The following is a description of a gene set: species: Mus musculus Combining with a protein hormone to initiate a change in cell activity. Mouse Gene Set: GOMF_PROTEIN_HORMONE_RECEPTOR_ACTIVITY, and this is the list of marker genes: Fgfr3, Mup2 (NCBI Gene Id 17841), Adipor1, Ntrk2, Tek (TEK receptor tyrosine kinase), Ntrk3, Ntrk1, Tie1, Ephb1, Fgfr4, Ddr1, Erbb2, Mertk, Mup11, Gpr173, Lgr5 (NCBI Gene Id 14160), Ror2, Epha1, Flt1, Epha3, Tshr (thyroid stimulating hormone receptor), Mchr1, Kit, Csf1r, Ret, Gnrhr, Mst1r, Amhr2, Lepr, Ros1, Met, Ephb4, Musk, Ephb2, Fshr, Alk, Mup3, Axl, Insr, Egfr, Ltk, Mup1, Mup5, Kdr, Cmklr1, Epha5, Fgfr2, Epha6, Adipor2, Mup4, Cmklr2, Pdgfrb, Epha10, Epha2, Epha8, Tyro3, Epha4, Ephb3 (NCBI Gene Id 13845), Extl3, Fgfr1, Ddr2, Lhcgr, Pdgfra, Flt4, Lgr6, Insrr, Lgr4, Flt3, Erbb4 (NCBI Gene Id 13869), Rxfp2, Epha7, Igf1r